Given this list of marker genes Grb2, Mmp3, Egfr, Prkca, Hras, here is a description of the gene set: electronically inferred by orthology from the curated human pathway This event has been computationally inferred from an event that has been demonstrated in another species.<p>The inference is based on the homology mapping from PANTHER. Briefly, reactions for which all involved PhysicalEntities (in input, output and catalyst) have a mapped orthologue/paralogue (for complexes at least 75% of components must have a mapping) are inferred to the other species. Reactome Pathway: EGFR Transactivation by Gastrin part of: Gastrin-CREB signalling pathway via PKC and MAPK studied in species Mus musculus